Given this list of marker genes Smad1, Tspan18, Hif1a, E2f2, Stard13, Klf4, S100a1, Dsg2, Jak1, Creb3l1, Jmjd8, Vegfa, Glul, Cemip2, Shh, S2bpcox16, Sema6a, Pkm, Zfp354c, Sh2b3, Epn1, Ghrl, Sec1, Epn2, Adamts9, Fut1, Tnn, Hmgb1, Thbs1, Bmper, Synj2bp, Pdpk1 (NCBI Gene Id 18607), Itga5, Ppp1r16b, Fgf1, Pik3cb, Tjp1, Slc39a12, Klf2, Ghsr, Alox5, Flt1, Rhoj, Ceacam1, Tgm2, Fgf2, Dll1, Il10, Clic3, Jcad, here is a description of the gene set: Mouse Gene Set: GOBP_REGULATION_OF_SPROUTING_ANGIOGENESIS studied in species Mus musculus Any process that modulates the frequency, rate or extent of sprouting angiogenesis.